The following is a description of a gene set: Lewy bodies Human Gene Set: HP_LEWY_BODIES studied in species Homo sapiens, and this is the list of marker genes: EIF4G1, GRN, ATXN3, SNCB, GBA1, PSEN1, C19orf12, CHMP2B, MAPT, VCP, RAB39B, MT-TT, ADH1C, TIA1, ATXN8OS (ATXN8 opposite strand lncRNA), ATXN2, NR4A2, SNCA, SNCAIP, LRRK2, FBXO7, TBP, TREM2, VPS35, DNAJC13, PLA2G6, TMEM106B, GIGYF2, PRKN, VPS13C (NCBI Gene Id 57581)